Given this list of marker genes Actr3, Filip1l, Tsc22d3, Pik3r5, Dctn2, H2-Eb1, Bcl2l14, Cfl1, H2-Aa, Slc27a3, Cd74, here is a description of the gene set: Cytokines mediate cell-cell communication in the immune system and represent important therapeutic targets. A myriad of studies have highlighted their central role in immune function, yet we lack a global view of the cellular responses of each immune cell type to each cytokine. To address this gap, the authors created the Immune Dictionary, a compendium of single-cell transcriptomic profiles of more than 17 immune cell types in response to each of 86 cytokines (>1,400 cytokine-cell type combinations) in mouse lymph nodes in vivo. A cytokine-centric view of the dictionary revealed that most cytokines induce highly cell-type-specific responses. For example, the inflammatory cytokine interleukin-1β induces distinct gene programmes in almost every cell type. A cell-type-centric view of the dictionary identified more than 66 cytokine-driven cellular polarization states across immune cell types, including previously uncharacterized states such as an interleukin-18-induced polyfunctional natural killer cell state. from publication Cui A, Huang T, Li S, Ma A, Pérez JL, Sander C, Keskin DB, Wu CJ, Fraenkel E, Hacohen N (PMID 38057668) Mouse Gene Set: CUI_MIGDC_LIF_RESPONSE_UP Genes positively differentially expressed in cell type: MigDC (migratory dendritic cell) upon treatment with cytokine: LIF in mouse lymph nodes in vivo. species: Mus musculus